The following is a description of a gene set: Human Gene Set: GOBP_NEGATIVE_REGULATION_OF_RESPONSE_TO_TUMOR_CELL species: Homo sapiens Any process that stops, prevents, or reduces the frequency, rate, or extent of a response to tumor cell., and this is the list of marker genes: TGFB1, AHR, CEACAM1, MAPK3, UFL1, CD274, HAVCR2, IL4I1, USP5, PDCD1